Given this list of marker genes Socs1, Stat3, Gbp4, Serpina3g, Ldah, Tlr7, Irf1, Hadhb, Nlrc5, Psmb9, Irgm1, Ifi47, Pml, Ppp3ca, Ffar1, Pkib (NCBI Gene Id 19081), Parp14, Tmco4, Stat2, Ly6a, Ptpn1, Tapbpl, Gbp5 (NCBI Gene Id 229898), Gbp7, Stat1, Eif3j1 (eukaryotic translation initiation factor 3, subunit J1), Tmsb10, here is a description of the gene set: Genes positively differentially expressed in cell type: B cell upon treatment with cytokine: IL-36α in mouse lymph nodes in vivo. Cytokines mediate cell-cell communication in the immune system and represent important therapeutic targets. A myriad of studies have highlighted their central role in immune function, yet we lack a global view of the cellular responses of each immune cell type to each cytokine. To address this gap, the authors created the Immune Dictionary, a compendium of single-cell transcriptomic profiles of more than 17 immune cell types in response to each of 86 cytokines (>1,400 cytokine-cell type combinations) in mouse lymph nodes in vivo. A cytokine-centric view of the dictionary revealed that most cytokines induce highly cell-type-specific responses. For example, the inflammatory cytokine interleukin-1β induces distinct gene programmes in almost every cell type. A cell-type-centric view of the dictionary identified more than 66 cytokine-driven cellular polarization states across immune cell types, including previously uncharacterized states such as an interleukin-18-induced polyfunctional natural killer cell state. species: Mus musculus from publication Cui A, Huang T, Li S, Ma A, Pérez JL, Sander C, Keskin DB, Wu CJ, Fraenkel E, Hacohen N (PMID 38057668) Mouse Gene Set: CUI_B_CELL_IL36A_RESPONSE_UP